Given this list of marker genes GNAI3, RD3, GALR1, GABBR2, CCR2, EDNRB, ADGRV1, GNAI2, AKAP5 (A-kinase anchoring protein 5), GRM2, GRM3, LTB4R2, here is a description of the gene set: Any process that stops or reduces the rate of lyase activity, the catalysis of the cleavage of C-C, C-O, C-N and other bonds by other means than by hydrolysis or oxidation, or conversely adding a group to a double bond. Human Gene Set: GOBP_NEGATIVE_REGULATION_OF_LYASE_ACTIVITY species: Homo sapiens